Given this list of marker genes THAP9-AS1, SULT1E1, PIGH, HSF2, MARS1, HSPA5, PPP2CA, ELF4, DYRK4, SNW1, XPC, PYCR1, CDKN3, MCFD2, NEK3, EGFR, UVRAG, CCNH, ZNF165, DCTN2, EPS8, ADAM8, DYRK1A, AARS1, TSG101, COL11A1, LMO4, CCDC85B, GNL2, HNRNPD, DUSP1, UBE2S, MICB, SNRPA1 (NCBI Gene Id 88988), DR1, BMP2, MIA2, ATF3, RCOR1, CYC1, CLPP, SLC33A1, EPHA2 (NCBI Gene Id 1969), ALKBH1, FOXD1, TGIF1, SHMT2, PPP2R2A, MAPK9, HSD17B8, GOT1, TOMM34, TNC, TRPC1, MRPL49, CBLB, RBM10, CCNA1, ZFP36, DGUOK, GSS, PSMD4, FGF2, DDX10, IL10RB, H1-10, WASF1, PRRC2A, XBP1, SRSF11, CD55, KLF5, CKAP5, CDK4, SH3BGR, HERPUD1 (homocysteine inducible ER protein with ubiquitin like domain 1), CDC6, AHR, DYNLT1, BCL7B, EIF2S1, ATXN2L, NELFE, NUP88, MTHFD2, ASNS (NCBI Gene Id 440), CREBBP, COMMD1, CXCL2, SRP19, RPP30 (ribonuclease P/MRP subunit p30), PTGS2, STK3, JOSD1, PIGA (NCBI Gene Id 5277), KDM5C, R3HDM1, GATA6, INTS9, CDKN2A, ILF2, GK, IL13RA2, G6PD, EXOSC7, AIMP1, SMAD1, ETV6, EWSR1, CEP57, MRPL58, TCEA1, PCCB, LHFPL2, UFM1, HYOU1, MLH1, UQCRFS1, PSMD11, ABI2, PPP1R11, NFKB1, PPWD1 (peptidylprolyl isomerase domain and WD repeat containing 1), CEBPG (CCAAT enhancer binding protein gamma), GFPT1, TOP1, FERMT2, GTF2E2, DAP, CTH (cystathionine gamma-lyase), SMAD7, ENOX2, NPC1, NFIL3, GPKOW, RAE1, NFX1, APBB2, ZNF274, PSMD7 (proteasome 26S subunit, non-ATPase 7), SLC1A5, CEBPD, PSMD9, EPCAM, CBX5, here is a description of the gene set: Genes consistently up-regulated in HMEC cells (primary mammary epithelium) upon expression of TERT off a retroviral vector. studied in species Homo sapiens Human Gene Set: SMITH_TERT_TARGETS_UP from publication Smith LL, Coller HA, Roberts JM (PMID 12717449) Most somatic cells do not express sufficient amounts of telomerase to maintain a constant telomere length during cycles of chromosome replication. Consequently, there is a limit to the number of doublings somatic cells can undergo before telomere shortening triggers an irreversible state of cellular senescence. Ectopic expression of telomerase overcomes this limitation, and in conjunction with specific oncogenes can transform cells to a tumorigenic phenotype. However, recent studies have questioned whether the stabilization of chromosome ends entirely explains the ability of telomerase to promote tumorigenesis and have resulted in the hypothesis that telomerase has a second function that also supports cell division. Here we show that ectopic expression of telomerase in human mammary epithelial cells (HMECs) results in a diminished requirement for exogenous mitogens and that this correlates with telomerase-dependent induction of genes that promote cell growth. Furthermore, we show that inhibiting expression of one of these genes, the epidermal growth factor receptor (EGFR), reverses the enhanced proliferation caused by telomerase. We conclude that telomerase may affect proliferation of epithelial cells not only by stabilizing telomeres, but also by affecting the expression of growth-promoting genes.